Given this list of marker genes Zranb3, Tsen34, Tmbim6, Dnase1, Ear1, Mrpl44, Ang4, Cwf19l1, Rida, Prorp, Elac2, Apex1, Xrcc1, Ankzf1, Rnaset2a, Tsn, Mre11a, Rpp14, Ybey, Zc3h12c, Slfn8, Rpp38 (NCBI Gene Id 227522), Dnase1l3, Ercc1, Pgbd5, Nudt16l2, Endog, Pop7, Smg6, Rpp30, Dnase2a, Rexo4, Tsnax, G3bp1, Nudt12, Ear14 (NCBI Gene Id 53877), Rbbp8 (retinoblastoma binding protein 8, endonuclease), Rnase2b, Pms2, Dclre1c, Rag1, Eme1, Endod1, Ago4, Ptbp1, Aste1, Piwil1, Pop4, Dna2, Elac1, Cpsf3, Ankle1, Polq, Rnasel, Dicer1, Lactb2, Alkbh2, Rpp21, Drosha, Nudt16l1, Ago2, Dffb, Rnaset2b, Exo1, Mblac1, Ear2, Dbr1, Rcl1, Rad50, Bivm, Ercc5, Rnaseh1, Exog, Ercc4, Dis3, Rpp25, Nynrin, Pop5, Apex2, Ang5, Slfn9, Abce1, Rnase1, Zc3h12a, Khnyn, Tdp2, Rps3, Rnase6, Xrcc3, Rnase4, Alkbh3, Ang, Nob1, Tsen2, Las1l (LAS1-like (S. cerevisiae)), Pld6, Zc3h12b, Rpp40, Eme2, Nudt16 (NCBI Gene Id 75686), Setmar (NCBI Gene Id 74729), Dnase1l1, Rnaseh2a, Gen1, N4bp2, Endov, Fan1 (NCBI Gene Id 330554), Ern2, Ang2, Mus81, Piwil4, Piwil2, Xrcc4, Endou, Dnase1l2, Snd1, Slfn14, Aplf, Ern1, Dnase2b (NCBI Gene Id 99669), Ints11, Zc3h12d, Fen1, Slx1b, Rnasek, Ago3, Rad51c, Pop1, here is a description of the gene set: studied in species Mus musculus Catalysis of the hydrolysis of ester linkages within nucleic acids by creating internal breaks. Mouse Gene Set: GOMF_ENDONUCLEASE_ACTIVITY